The following is a description of a gene set: Catalysis of the removal of a methyl group from a protein. species: Mus musculus Mouse Gene Set: GOMF_PROTEIN_DEMETHYLASE_ACTIVITY, and this is the list of marker genes: Kdm4a, Kdm1a, Rsbn1, Kdm6b, Kdm7a, Kdm2a, Kdm3b, Kdm5c, Kdm3a, Riox2, Phf8, Hr, Jmjd6, Fbxl19, Kdm5b (NCBI Gene Id 98723), Kdm4c, Kdm4dl, Jarid2, Uty, Kdm5a, Riox1, Kdm8, Kdm2b, Kdm5d, Kdm1b, Jmjd1c, Phf2, Kdm6a, Kdm4d, Kdm4b